The following is a description of a gene set: Human Gene Set: HP_SHALLOW_ANTERIOR_CHAMBER Reduced depth of the anterior chamber, i.e., the anteroposterior distance between the cornea and the iris is decreased. Shallow anterior chamber studied in species Homo sapiens, and this is the list of marker genes: RAB18, FZD4, ADAMTS10, ASPH, NDP, ATOH7, PGAP2, PIGW, PGAP3, ANTXR1, PIGV, PIGY, FBN1, PIGL, ADAMTS17, LTBP2, PIGO, TSPAN12